Given this list of marker genes Fgfr1, Dgat1, Ddr2, Pdgfrb, Cygb, Gsk3b, Nr1d1, Acta2, Myb, Akap12, Smo, Lep, Rps6ka1, Gclm, Gclc, Ugt1a1, Rian, Pdgfb, Myocd, here is a description of the gene set: Mouse Gene Set: GOBP_HEPATIC_STELLATE_CELL_ACTIVATION A change in the morphology or behavior of a hepatic stellate cell resulting from exposure to a cytokine, chemokine, hormone, cellular ligand or soluble factor. studied in species Mus musculus